Given this list of marker genes CHMP6, CALML6, TUBB8B, RAB6C, CCP110 (centriolar coiled-coil protein 110), CEP250, OFD1, RAB11A, HAUS6 (HAUS augmin like complex subunit 6), CDC14B, RSPH9, MISP, CCDC39, KIFBP, OBSL1 (NCBI Gene Id 731094), PIERCE2, FLNA, HTT, TUBD1, ZMYND10, CIB1, DYRK1A, INCENP, UBE2B, SLC16A1, CLTC, TUBB1, NIN, CDK2, KPNB1, KIF14, PLK3, SUN2, MAP10, CKAP2, DLGAP5, TUBAL3, EZR, PAK1, AFG2B, SSNA1, WEE1, CUL9, PAX6, CCDC63, STMN3, NEK7, BBS2, LRRC23 (leucine rich repeat containing 23), LRGUK, CDCA8, MZT1, KIF11, PIBF1, ZW10, CENPE, KIFC1, TOGARAM2, DYNC1H1, CCDC66, TUBB3, CENPH, CDC20B, NUF2, DEUP1, KIF24, GSK3B, FBXW11, PPP2R1B, INPP5J, MEIG1, DST, CHMP4B, RANBP10, GAPDH, UXT, CCDC187, AURKB, PCNT, TEKT2, DLG1, CCDC65, PPP1R35, CLIP3 (CAP-Gly domain containing linker protein 3), MAPRE3, BLOC1S2, LIMK2, GAS2L3, CHMP4C, SIK3 (SIK family kinase 3), PRC1, KIF4A, POC1A, DNAAF11, SKA3, DNAI2, DIXDC1, TTLL3, CDK11A, SPEF1, SPRY2, NUBP1, ZNF207, HNRNPU, TUBB4A, NTMT1, CDK5RAP2, DCTN1, NEFL, CFAP58, APC2, NUP62, FES (FES proto-oncogene, tyrosine kinase), FGF10 (NCBI Gene Id 2255), TACC2, TPX2, DNAJB13 (DnaJ heat shock protein family (Hsp40) member B13), KATNBL1, LLGL1, DNAH2, TTLL7, FER, CDKN1B, CFAP65, PPP1R12A, HAUS7, TUBA8, POLDIP2, CAMSAP3, TUBA4A, ANKFN1, MAP1S, HAUS3, IFT56, KIAA0753, KIF18B (kinesin family member 18B), WRAP73, KASH5, TRIM54, PARD6B, HOATZ, CEP20, ROCK1, CDH5, ATRX (NCBI Gene Id 6475), SKA1, DIAPH3, TACC1, TPPP, ATAT1, SPIRE1, TUBG2, WDR62, NAT10, C2CD3, UBXN2B, TUBG1 (NCBI Gene Id 7283), DCLK2, ARHGEF7, INPPL1, PTPA (NCBI Gene Id 5524), FBXO24, CHMP1A, SENP6 (NCBI Gene Id 26054), XRCC3, CHD3, USP33, SPAG16, C10orf90, ENKD1, HAUS8, TBC1D21, TPPP2, DCTN2 (NCBI Gene Id 1640), PPFIBP1, MID1IP1, APC, SPATA7, EFNA5, CCNL1, TACC3, CCDC170, TXNDC9, DNAH17, CNTLN, TPR, MAPRE2, HOOK1, EML2, MAP7, DRC1, PPP2CA, KIAA1614, MLH1, TBCD, AXIN1, KIF18A, TUBB2B, MAP1B, MCPH1, BBS4, FAM110A, FOXJ1, BCAS2, PKD2, FBXO5, CDK2AP2, TAOK1, ODAD1, MARK3, BICD2, CSNK1D, DNAI3, SASS6, TOGARAM1 (NCBI Gene Id 23116), EML3, TUBB8 (NCBI Gene Id 347688), CKAP5, GPSM2, PKD1, TTLL1, CFAP43, HAUS1, SRGAP2C, SPAG6, GOLGA2, CDC20, CEP350, GTF2B, TUBB6, DRG1, CFAP206, DNAAF2, GJA1, TUBA3E, CEP72, CHMP5, MOS, INO80, CCDC146, E2F4, CFAP73, CTNNB1 (catenin beta 1), ODAD4, CCDC69, RANGRF, CEP85, DNAAF5, MAP2 (microtubule associated protein 2), PAFAH1B1, NEK2, TPGS1, KIF3B, EFCAB11, STAG1, XRCC2, NINL, CGN, STMN1, TUBA3D, TUBE1, SGO1, ANKRD53, CCDC61, SPDL1, CFAP44, ASPM, CFAP100, CENPA, FKBP4, PCLAF, CHP1, SPEF2, MAPRE1, CFAP91, NUMA1, STK36, CHMP3, PLK1, SDCCAG8 (SHH signaling and ciliogenesis regulator SDCCAG8), RPS3, TBCEL, NDEL1, CCNF, NAV1, CNTROB, HDAC6 (histone deacetylase 6), STMND1, CFAP46, CDK5, SETD2, KAT2B, CALML4, PARD3, PEX14, DCAF13, DNAH5, TLE6, CPLANE2, DAG1, KIF2C, ITGB1BP2, DOCK7, RHO (NCBI Gene Id 6010), KIF4B, KNSTRN, PDCL2, AKAP9, GPSM1, CFAP57, RANBP9, ABRAXAS1, EPHA3, FSD1, SPIRE2, CAPN6, CAMSAP2, BBS1, GAS8, PARD6G, SPAST, FIGNL2, TTLL5, PLK2, MARK1, BCCIP, PDCD6IP, KIZ, WASHC5, PPP2CB, CAMSAP1, NLRP5, CHMP4BP1, HDGFL3, PHLDB1, RCC1, ODAD3, LRRC46 (NCBI Gene Id 90506), DNAH1 (NCBI Gene Id 25981), TUBGCP3, RTTN, SNCA, CCNB1, HEPACAM2, FMN2, TTLL9, ODF2 (NCBI Gene Id 4957), NCKAP5, SPECC1L (sperm antigen with calponin homology and coiled-coil domains 1 like), TUBGCP4, GABARAP, KIF3A, GCC2, VCP, SBDS, BRCA2, CEP135, ARHGEF2, ZPR1, BIRC5, EML1, RAN, KAT5, CLASP1, INTS13, CHEK2, SAPCD2, MAP4, CC2D2A, TRAF3IP1, PARP3, AURKA, CROCC, CDC14C, SRGAP2, AUNIP, CHMP7, CCNL2, ATF5, CHORDC1, CCSAP, POC5, CAV3, MTCL1, CEP152, MARK4, HOOK3, TTLL13, TRIM36, RBM14, RANBP1, STMN4, IFT172, FAM107A, MAP6, CCDC13, SPACA9, CCDC102B, LMNA, WNT3A, DNAAF3, RAC1, CFAP47, KAT2A, TTLL11, BMERB1, TUBA1A, PIERCE1, CEP76, CFAP69, GEN1, RACGAP1, CCDC103, TTL, DNM2, PARD6A, SSX2IP, CALML5, SLK, TRIM46, ATXN3, KATNA1, SPRY1, UHRF1, PRICKLE1, STAG2, KIF2B, CLUAP1, CCDC8, DNAI1, FBXW5, CNTN2, TTLL4, CSAG1, IQCA1L, BICD1, PLA2G3, NDC80, TUBB4B, MAP1A, CHEK1, FGF13, TBCE, CETN1, RIPOR2, KATNAL1, HYDIN, NCKAP5L, RNF4, ARMC2, RAE1, MAP6D1, SS18, XPO1, TTBK2, PTEN (NCBI Gene Id 8037), HOOK2, SEPTIN1, GSK3A, PRKAA2, CEP295, FSIP2, CEP44, CLASP2, IQCG (NCBI Gene Id 84223), SLAIN2, CCSER2, KIF15, CYLD, BRSK1, TMEM67, CCDC120, ATXN7, DZIP1, TUBB, MAPT, CFAP157, CCDC68, CEP295NL, CCDC88A, CLIP2, DNAI4, KATNAL2, CCDC57, KATNB1, NME7, TTLL6, TUBB2A, MECP2, NDE1, TTK, DCX, WDR47, DNAAF4, CCDC88C, ALMS1, HSPA1B, TUBA1B, MNS1, ZMYND12, SLC39A12, HDAC3, MAP7D3, PRUNE1, CETN2, MAPK15, TPPP3, CFAP74, IQCA1, KIF21A, KIF20A, CLXN, PLK4, SUN1, NUDC, SIRT1, CCDC42, NEFH, PKHD1, MYBL2, SUGT1, DCTN6, CLIP4, RSPH6A, DNAH8, MDM1 (NCBI Gene Id 56890), STMN2, JHY (junctional cadherin complex regulator), PRKCZ, MID1, LSM14A, DYNC1LI1, SPAG5, DISC1, BBOF1, RNF19A, FIGN (NCBI Gene Id 80249), OOEP, SPAG1 (NCBI Gene Id 6674), SPAG17, CCDC78 (NCBI Gene Id 64742), DNAAF1, MAP7D1, RMDN1, CDK1, CRYAB, CEP97, TTLL8, CEP43, CUL7, PPFIA1, CCNB2, HAUS2, DVL1, CEP68, SLAIN1, TUBGCP2, BRSK2, SKA2, SPC25, CEP63, PHLDB2, ABRAXAS2 (NCBI Gene Id 96567), DYNC1LI2, BRCA1, ESPL1, CCDC15, ARL2, TUBGCP5, CEP19, KIF23, AURKC, MAP9, STARD9, MYH9, DDB1, KIF2A, RSPH4A, CEP70, DNAAF6, SON, ABL1, BORA, MARK2, GAS2L1, DAW1, RHOA, SMC1A, CEP131 (centrosomal protein 131), ODAD2, ROCK2, PPP2R3C, ITGB1, TRPV4, HAUS4, TRDN, TUBA1C, RP1, DNAAF8, CHMP1B, DYNLT1, PIN1, TTC12, POC1B, CHMP4A, DNAH7, CRIPT, OCLN, GNAI1, STIL, NAV3, PDE4DIP, GAS2L2, CENPJ, NCOR1, SAC3D1, CETN3, MAD2L1, PLK5, CCDC88B (coiled-coil domain containing 88B), TBCB, GBA2, CFAP97D1, PPP2R1A, FIGNL1, ZBED3, NEURL1, ILK, MET, NEDD1, WDR90, ULK4, KIF25, KIF19, TNKS, RP1L1, PSRC1, TUBGCP6, CCDC40, DRC7, CFL1, TUBA3C, UVRAG, HAUS5, SMC3, HSPA1A, BCL2L10, VPS4B, NPM1, PRKAA1, CDC14A, DNAL1, CHMP2A, GIT1, CLIP1, CENATAC, TLN1, WDR73, CDK11B, AAAS, CEP126, PCM1, LLGL2, LRRC61, SPICE1, TTLL2, RGS14, CEP120, EML4, MAP7D2, CHMP2B (NCBI Gene Id 7877), EFHC1, RSPH1, DNAAF10, PARD3B, LZTS2, SYNE2, ARHGEF10, GADD45A, KANK1, NUSAP1, MCIDAS, CEP192, TRIM37, NEK6, CDK5R1, BNIP2, NSFL1C, here is a description of the gene set: A process that is carried out at the cellular level which results in the assembly, arrangement of constituent parts, or disassembly of cytoskeletal structures comprising microtubules and their associated proteins. Human Gene Set: GOBP_MICROTUBULE_CYTOSKELETON_ORGANIZATION studied in species Homo sapiens